Given this list of marker genes CHTF18, POT1 (NCBI Gene Id 25913), CDK2, RUVBL2, CCNA2, POLD3, CCNA1, PPP6R3, DNA2, PIF1, RPA2, LIG1 (DNA ligase 1), ANKRD28, POLD4, WRN, ACD, POLD2, TERF1, DSCC1, PPP6C (NCBI Gene Id 96749), BLM, WRAP53, PRIM1, TERT, RTEL1, TEN1, CHTF8, PRIM2, NHP2, PCNA, RFC3, SHQ1, RFC4, RFC1, POLD1, POLA2, RFC5, RFC2 (replication factor C subunit 2), TINF2, RPA1, RUVBL1, RPA3, TERF2, NOP10, POLA1, DKC1, GAR1, CTC1, FEN1, STN1, TERF2IP (NCBI Gene Id 54386), here is a description of the gene set: Telomerase acts as reverse transcriptase in the elongation of telomeres (Smogorzewska and de Lange 2004). studied in species Homo sapiens part of: Telomere Maintenance Reactome Pathway: Extension of Telomeres